The following is a description of a gene set: Interactome of polycomb repressive complex 2 (PRC2) studied in species Homo sapiens Human Gene Set: WP_INTERACTOME_OF_POLYCOMB_REPRESSIVE_COMPLEX_2_PRC2, and this is the list of marker genes: ELL, MTF2, THRAP3, EZH1, RBBP7, SETX, EZH2, JARID2, STK38, SUZ12, MORC3, BCLAF1, AEBP2, EED, RBBP4, TRIM35